The following is a description of a gene set: species: Homo sapiens The accumulation and maintenance in cells or tissues of a nutrient, a substance that is used by an organism to survive, to grow, and to reproduce; such as proteins, vitamins, and minerals. Nutrient reserves can be accumulated for mobilization and utilization when needed. Human Gene Set: GOBP_NUTRIENT_STORAGE, and this is the list of marker genes: ITGB3 (integrin subunit beta 3), MIR10B, GBA1, FFAR2, PISD, ACACB, CD36 (NCBI Gene Id 948), DGAT2, NFKB1, MIR144, AUP1, NRIP1, LEP, PTPN2, PLA2G4C, SREBF1, CLSTN3, DGAT1, CDS2, HEXA, NFKBIA, LRAT, SOAT2, C3, PPARD (NCBI Gene Id 5467), MIR146A, OOEP, CES1, NPC1, STAT5B, VSTM2A, CRP, CIDEA, IKBKE, APOB, BSCL2, ALKBH7, HILPDA, NEGR1, CPT1A, CRY1, NR1H2, B4GALNT1, SIRT1, NPC2, ZC3H12A, PADI6, PPARG, NR1H3, FTO, CDS1, EHD1, GM2A, PLIN3, PNPLA2, ZFYVE1, APOC4, FBXW7, SCARB1, ITGAV, FITM2, PLA2G10, TREM2 (triggering receptor expressed on myeloid cells 2), ANGPTL3, LIPA, TNF, APOA1, SREBF2, STARD4 (NCBI Gene Id 154899), PLIN5, CIDEB, CAV1, TLE6, CIDEC, TTC39B, ABCG1 (ATP binding cassette subfamily G member 1), ABCA1, RNF213, HEXB, LPL, MEST, LDAF1, MSR1, KHDC3L, FITM1, SOAT1, PPARA, SMIM22, MOSPD2, ABHD5, SQLE, MIR34A, IL6, APOE, STAT5A, NLRP5, CRY2, PLIN2, LDAH, ACVR1C